The following is a description of a gene set: Any process that activates or increases the frequency, rate or extent of gonad development. Human Gene Set: GOBP_POSITIVE_REGULATION_OF_GONAD_DEVELOPMENT studied in species Homo sapiens, and this is the list of marker genes: DHX37, WT1, ZFPM2, NR5A1 (nuclear receptor subfamily 5 group A member 1), SRY, CITED2, RETN, DMRT1, SOX9